The following is a description of a gene set: Ion transport by P-type ATPases species: Homo sapiens Human Gene Set: REACTOME_ION_TRANSPORT_BY_P_TYPE_ATPASES, and this is the list of marker genes: ATP11B, ATP10A, CAMK2B (NCBI Gene Id 816), ATP4B, CALM1, ATP7B, ATP2B2, ATP2C1, ATP13A2, FXYD6, FXYD7, FXYD4, ATP10B, ATP2B1, PDZD11, ATP8A1, CAMK2G, ATP1A2, ATP2A2, ATP2C2, ATP8B2, ATP4A, ATP12A, ATP13A4, ATP9A, ATP10D, PLN, ATP2A3, CAMK2A, ATP1B2, ATP1B1, CAMK2D, ATP1B3, ATP13A1, SRI, SLN, ATP2A1, ATP2B4, ATP8A2, ATP9B, FXYD3, ATP7A, ATP2B3, ATP13A5, FXYD1, ATP8B4, CUTC, ATP8B3, ATP1A3, ATP8B1, ATP11A, ATP1A4, ATP1A1, ATP11C, FXYD2